The following is a description of a gene set: studied in species Homo sapiens A process involved in the controlled movement of a bacterial cell powered by the continuous polymerization of actin at one pole of the cell. Human Gene Set: GOBP_ACTIN_POLYMERIZATION_DEPENDENT_CELL_MOTILITY, and this is the list of marker genes: ENAH, ARPC2, EPS8, JMY, NCKAP1L, ACTR3, ARPC3